Given this list of marker genes SPTBN1, HSPD1, TMEM63A, PPP2R2B, GBA2, KIF1C, PLP1, IFRD1, LAMA1, PEX6, AARS1, GJC2, PI4KA, ITPR1, SPG11, SIGMAR1, CACNA1G, CIZ1, LMNB1, NOTCH2NLC, AFG3L2, NPTX1, KCNN2, NEFL, SPTLC1, TTPA, NOP56, SCP2, SH3TC2, KARS1, HIBCH, POLR1A, FUS, NKX6-2, SETX, ANO3, UCHL1, EIF2AK2, ALS2, DNMT1, VPS13A, TRIM8, PIGA, RNU12, PIK3R5, CEP104, STUB1, here is a description of the gene set: Human Gene Set: HP_HEAD_TREMOR species: Homo sapiens Head tremor An unintentional, oscillating to-and-fro muscle movement affecting head movement.